The following is a description of a gene set: from publication Chen Y, Wang X (PMID 31504780) Genes predicted to be targets of miRBase v22 microRNA mmu_miR_465a_5p in miRDB v6.0 with MirTarget v4 prediction scores > 80 (high confidence targets). studied in species Mus musculus Mouse Gene Set: MIR_465A_5P, and this is the list of marker genes: Mogs, Zfp60, Lrrtm4, Card19, Avl9, Actr2, Rbfox1, Ccdc85a, Arrdc3, Gmcl1, Lrrc57, Srrm1, Myo19, Gm10778, Naa30, Thoc2, Mmp24, Dmrta1, Pof1b, Lin9 (lin-9 DREAM MuvB core complex component), Eny2, Esp31, Sbno1, Ube2w, Fnip1, Foxa2, Samt1d, Susd6, Rnls, Strap, Il1rap, Crebrf, Ms4a2, Cbx8, Ccdc88a, Dgkb, Lca5, Nhlh2, Cdh5, Rev3l, Cxadr, Sgpp1, Cox16, Gucy1a1, Nudt4, Trub1, Tecrl, Phf8, Tiprl, Gabrg1, Slc25a22, Nup205, Kpna3, Adhfe1, Ugt2a3, Tspan13, Rfx3, Efhc1 (EF-hand domain (C-terminal) containing 1), Casp8, Baz2a, Kera, N4bp1, Glcci1, Corin, Ap3s1, Gpr21, Zfp729b, Acbd5, Ints5, Lyn, Fgd4, Gabra4, Epm2aip1, Serpinb11, Capn3, Rsf1 (NCBI Gene Id 77334), Fam185a, Krtap15-1, Vta1, Zfp248, Armcx5, Oaz1, Mmd, Syde2, Zdbf2, Socs6, Kcnj2, Btbd1, Samt1, Unc93a, Stag2, Pla2g3, Ppfibp1, Napepld, Pla2g5, Lin28b, Gins3, Hopx, Trib2, Alg6, Pfkfb2, Ranbp3l, Cyp4a31, Ehd4, Mdh1, Entr1, Secisbp2l, Pank3, Sypl1, Gm16445, Klhl12, Celf3, Boc, Cfap20, Ubl3, Irf2, Fndc10, Mark3, Rnf113a2, Foxb1, Lrrtm2, Hnrnpr, Tti2, Nup62, Morn1, Tmem263, Esp34, Gabra6, Gosr1, Chic1, Batf, Msl3, Ankra2, Sec11c, Cpeb2, Parp8, Fbxo4, Mcm8, Actl6a, Samt1b, Ptk2, Treml1, Tra2b, Adam28, Prkcd, Hand1, Slc7a11, Mtdh, Zfp148, Wdfy3, Kcnab1, Sim1, Krt6a, 1110004F10Rik, Osbpl8, Alg14, Mat2b, Pigp, Nhs, Kndc1, Zfp747, Slco2b1, Lhcgr, Tex12, Pwwp3b, Pex13, Wnt5b (wingless-type MMTV integration site family, member 5B), Cyp20a1, Samt1c, Pak1, Gpr85, Dpyd, Gria4, Trappc6b, Ltn1, Ube2s, Hs3st3a1, Kitl, Acadsb, Esp18, Aplf, Tspan14, Hspa4, Fam76b, Ptbp3, Zfp809, Smarca1, Rab14, Trim30b, Fbxl17, Exph5, Zmiz1, L2hgdh, Cngb1, Yipf3, Mpp4, Tcf12, Dip2a, Sox6 (SRY (sex determining region Y)-box 6), Csn1s1, Stc2, Naaladl2, Phf3, Efcab14, Tmtc3, Septin10, Ehmt1, Osbpl1a, Ptprk, Irf6, Cyp2j6, Snrpg, Zfpm2, Depdc7, Nt5e, Smc3, Itgb3bp, Sqor, Jam3, Mpp7, Ythdc2, Cpne8, Scn1a, Txndc5, Cdkl4, D17H6S53E, Snx13, Tle4, S2bpcox16, Zfp738, Tacc2, Psmd11, Noxo1, B020004C17Rik, Gucy1a2, Mlx, Cntn3, Ccdc87, Samd8, Cd9, Vwc2, Oat (ornithine aminotransferase), Tjp1, Pcdh9